The following is a description of a gene set: studied in species Homo sapiens Signaling by the B Cell Receptor (BCR) Human Gene Set: REACTOME_SIGNALING_BY_THE_B_CELL_RECEPTOR_BCR, and this is the list of marker genes: PPP3CB, IGLV2-11, PSMA7, IGKV3-11, PSMD3, NFATC2, BTRC, PSMA1, IGKV1D-39, CD79B, UBC, IGHV3-33, IGKV2-30, IGKV3-20, IGHV4-59, UBB, IGLV2-14, PLCG2, IGHV2-70, IGHV3-7, IGHV3-48, PPIA, NFKBIA, IGKV2-28, PSMA2, PSMD7, PSMA6, PSMC4, IGKV1-39, TRPC1, GRB2, IGHV1-69, IGKV4-1, IGKV1D-33, NFKBIE, CALM1, DAPP1, PSMD6, HRAS, IGHV1-2, PIK3CD, PSMD11, PPP3CA, RASGRP3, PSMA5, IGLV1-44, IGLV1-51, IGKV1-17, IKBKG, NFKBIB, IGHV3-30, PSMB4, PSMB6, IGHD, IGHV4-34, ITPR3, IGKV2D-28, SYK, CD79A, CUL1, PSMD1, BLNK, PIK3R1, SOS1, IGLC2, RPS27A, IGHM, IGLV3-21, PSMD13 (proteasome 26S subunit, non-ATPase 13), CD22, PSMB3, PSMB1, ITPR2, BCL10, PSMB7, PRKCB, NFKB1, IGHV3-53, IGKV3-15, PPP3R1, NRAS, KRAS, IGLV1-47, AHCYL1 (NCBI Gene Id 29039), IGHV2-5, IGLV3-1, IGKV3D-20, ORAI1, IKBKB, VAV1, IGLV2-23, MALT1, PSMC2, MAP3K7, PTPN6, SKP1, PSMD8, SEM1, IGKV5-2, PSMB5, IGLV7-43, IGLV6-57, RASGRP1, NFATC3 (NCBI Gene Id 82543), IGKV1-12, REL, FBXW11, PSMA4, IGHV1-46, IGKV1-5, IGKV1D-16, ITPR1, CHUK, ORAI2, UBA52, IGHV3-13, PSMD2, IGHV3-23, IGLV3-27, ADRM1, IGLC3 (NCBI Gene Id 3539), PSMC6, STIM1, IGLV3-25, PSMD12, IGKV1D-12, NCK1 (NCK adaptor protein 1), NFATC1, IGHV4-39, CARD11, PSMB2, PSMC5, PSMA3, FKBP1A (NCBI Gene Id 2280), PSMC3, PSMD14, IGHV3-11, PIK3AP1, IGKV1-16, IGKV1-33, FYN, CD19, IGLV3-19, IGLV2-8, BLK, SH3KBP1, IGLV1-40, RELA, BTK, IGKV2D-40, IGKV2D-30, LYN, PSMC1